The following is a description of a gene set: species: Homo sapiens from publication Mages J, Dietrich H, Lang R (PMID 18086374) Genes up-regulated in tolerant microphages: untreated versus LPS. Human Gene Set: GSE8621_LPS_PRIMED_UNSTIM_VS_LPS_PRIMED_AND_LPS_STIM_MACROPHAGE_UP Among the multiple mechanisms that control the intensity and duration of macrophage activation, the development of a state of refractoriness to a second stimulation in cells treated with LPS has long been recognized. Release of inhibitory cytokines and alterations in intracellular signaling pathways may be involved in the development of LPS tolerance. Although a number of molecules have been implicated, a detailed picture of the molecular changes in LPS tolerance is still missing. We have used a genome-wide gene expression analysis approach to (i) define which fraction of LPS target genes are subject to tolerance induction and (ii) identify genes that are expressed at high levels in tolerant macrophages. Our data show that in LPS tolerant macrophages the vast majority of LPS-induced gene expression is abrogated. The extent of tolerance induction varies for individual genes, and a small subset appears to be excepted. Compared to other negative control mechanisms of macrophages, e.g. IL-10-induced deactivation, LPS-tolerance inhibits a much wider range of transcriptional targets. Some previously described negative regulators of TLR-signaling (e.g. IRAK-M) were confirmed as expressed at higher levels in LPS-tolerant macrophages. In addition, we discuss other potential players in LPS tolerance identified in this group of genes., and this is the list of marker genes: PAFAH2, CHIC1, PTPA, COMT (NCBI Gene Id 1312), DNAJB2, EDC4, LAX1, LZTS2, NQO1, C19orf67, GBA2, ZNF512, SOX18, VEGFC, EIF4A3, SMAGP (small cell adhesion glycoprotein), LARGE2, SAFB2, RCN3, ATOSB (NCBI Gene Id 80256), DAP3, ZFP90, LEAP2, RING1, CAVIN3, RARG, MAP4K1, PITPNM1, PKN3 (protein kinase N3), EXTL3, AGPAT2, TMUB2, HSD3B7, MOB2, PTPRJ, RPL3, EML3, HSD17B10, CA11, ABHD16A, SEPTIN8, ATP6V1G2, TOR4A (torsin family 4 member A), BUD13, SLC44A1, GPSM3, ZNF428, DCAF8, RASGEF1B, AFDN, ATP5F1E, CDKN2D, DEXI, BTG3, ENSG00000286190, LTBR, TAF12, CSNK1G2, KLHL6, ZCCHC12, DDX5, SRFBP1, SRI, DCAF12L1, SMO, ANKRD13A, MAP2K5, MPRIP, RNASE6, AP3D1, NEFH, COL4A2 (NCBI Gene Id 1284), RPRM, ZCCHC24, MUC1, NFIC, ZNF189, PCLO, DAPK3, RAB27B, PLEKHO2, GAS6, DNTT, LIME1, ADRB2, TXN2, APPL2, FKBP8, SORBS1, PLEKHJ1, TECR, TEX264, NRIP1, FLRT3, GALNT6, RAB20, UBXN6, LYL1, CTTN, HGS, APLP2, CAPSL, PPIL2, BTD, PPDPF, MMAA, RPLP0, VMAC, TAF10 (NCBI Gene Id 6881), MARVELD2, TTC38, ACO2, PPARGC1A, TBRG1, LONP1 (NCBI Gene Id 9361), WDSUB1, PIM1, CTNNBL1, BTRC, MGAT1, S100PBP, MAEA, SYF2, AGPAT4, CHST7, SLC39A11, BCDIN3D, PKD2, LMNTD2, IMMP2L (inner mitochondrial membrane peptidase subunit 2), DMD, TRMU, EVA1B, DZIP1, SBSN, FNDC10, KLHL24, SLC25A23, LINC00511, WDTC1 (WD and tetratricopeptide repeats 1), VKORC1, FNBP1L, DUSP4, MARVELD1, TSC22D3, ICAM2, NPR2, TSEN54, FKBP10, SPG11, MAP3K8, CABP5, MGRN1, H1-2 (H1.2 linker histone, cluster member), MRPL52, PIP5K1C (phosphatidylinositol-4-phosphate 5-kinase type 1 gamma), TMEM106B, GALT, NLRC5, CTNNAL1, GRAMD1A, CERS4, SLC41A1, COL16A1, CDC42SE1, BEX4, FZD8, WTIP, IKBKB, CHAF1B, JOSD2, HSCB, RTL8B, ANTKMT, OTUD5 (OTU deubiquitinase 5), KHK, ISLR, MYLK, FLOT1, GP9, GKAP1 (NCBI Gene Id 80318), NUDT9, SUGP1, DMWD, IL2RG, SGMS1, SKIC2, RPL24 (ribosomal protein L24), SERTAD1, MYCT1, PYGB, EPB41L5, GABRA1, RRP9, ZNF608 (NCBI Gene Id 57507), RRP7A, ADI1 (acireductone dioxygenase 1), RPS10, RNF125